Given this list of marker genes RB1CC1, ULK2, ATG7, ATG5, ATG10, PIK3R4, ATG12, BECN1, ULK1, PIK3C3, MTOR, ATG13, ATG4A, ATG3, ATG16L1, ZFYVE1, ATG16L2, MAP1LC3A, WIPI1, here is a description of the gene set: Human Gene Set: WP_HOSTPATHOGEN_INTERACTION_OF_HUMAN_CORONAVIRUSES_AUTOPHAGY studied in species Homo sapiens Host-pathogen interaction of human coronaviruses - autophagy